Given this list of marker genes Scel, Ankrd1, Zfp638, Lypla1 (NCBI Gene Id 18777), Tpr, 2700099C18Rik, Dusp12, Cdk8, Arhgap5, Ccl7, Zfp62, Mapkapk2, here is a description of the gene set: species: Mus musculus The tumor suppressor protein BRCA1 has been shown to enhance p53 transcription, whereas activated p53 represses BRCA1 transcription. To further understand the functional interaction of these proteins, we investigated the role of BRCA1 in p53-induced phenotypes. We found that BRCA1 when subjected to forced expression acts synergistically with wild-type p53, resulting in irreversible growth arrest, as shown by VhD mouse fibroblast cells expressing a temperature-sensitive mutant of p53. Furthermore, reintroduction of both BRCA1 and p53 into BRCA1(-/-)/p53(-/-) mouse embryonic fibroblasts markedly increased the senescence phenotype compared to that induced by p53 alone. In particular, we found that BRCA1 expression attenuated p53-mediated cell death in response to gamma-irradiation. Moreover, microarray screening of 11 000 murine genes demonstrated that a set of genes upregulated by p53 is enhanced by coexpression of BRCA1 and p53, suggesting that BRCA1 and p53 exert a promoter selectivity leading to a specific phenotype. Taken together, our results provide evidence that BRCA1 is involved in p53-mediated growth suppression rather than apoptosis. Mouse Gene Set: ONGUSAHA_BRCA1_TARGETS_DN from publication Ongusaha PP, Ouchi T, Kim KT, Nytko E, Kwak JC, Duda RB, Deng CX, Lee SW (PMID 12802282) Genes down-regulated in MEF cells (embryonic fibroblast) lacking TP53 and BRCA1 by expression of BRCA1.